Given this list of marker genes HSPA2, TGFBI, TCF25, ID3, TNS2, CITED2 (NCBI Gene Id 154106), KLF9, MYCN, AMPD3, KLK1, SPSB1, IGF1R, BCL2L11, NBL1, ADAMDEC1, NDRG1, NAPSA, XRN1, DUSP1, RO60, HP, GADD45G, GADD45B, NR4A1, BHLHE40, KCNK2, XIST, SAT1, BCL6, AKAP8L, ENTPD5, DDX6, LTBP1, IRS2, PDK4, TFCP2L1, C1QTNF3, DDIT3, ACSS1, INMT, LRP6, TNXB, CFHR1, PEG3, MAP3K8 (mitogen-activated protein kinase kinase kinase 8), BMP4, ITPR2, MCM5, NET1, CFH (NCBI Gene Id 3076), WNK1, MSC, GDPD3, CXCL14, KRT7, MITF, CMC4, LEPR, FAM20C, PER2, TXNIP, CHD8, CEBPB, ALDH1A1, ZSCAN26, FOXO3, IGFBP3, CCN3, PARM1 (prostate androgen-regulated mucin-like protein 1), here is a description of the gene set: Human infertility and recurrent pregnancy loss caused by implantation defects are poorly understood. Hoxa-10-deficient female mice have severe infertility and recurrent pregnancy loss due to defective uterine implantation. Gene expression profiling experiments reveal that Hoxa-10 is an important regulator of two critical events in implantation: stromal cell proliferation and local immunosuppression. At the time of implantation, Hoxa-10 mediates the progesterone-stimulated proliferation of uterine stromal cells. Hoxa-10 mutants express a stromal cell proliferation defect that is accompanied by quantitative or spatial alterations in the expression of two cyclin-dependent kinase inhibitor genes, p57 and p15. Hoxa-10 deficiency also leads to a severe local immunological disturbance, characterized by a polyclonal proliferation of T cells, that occurs in place of the normal progesterone-mediated immunosuppression in the periimplantation uterus. Human Gene Set: YAO_TEMPORAL_RESPONSE_TO_PROGESTERONE_CLUSTER_1 Genes co-regulated in uterus during a time course response to progesterone: SOM cluster 1. studied in species Mus musculus from publication Yao MW, Lim H, Schust DJ, Choe SE, Farago A, Ding Y, Michaud S, Church GM, Maas RL (PMID 12554760)